The following is a description of a gene set: species: Homo sapiens from publication Schaefer CF, Anthony K, Krupa S, Buchoff J, Day M, Hannay T, Buetow KH (PMID 18832364) Syndecan-1-mediated signaling events Human Gene Set: PID_SYNDECAN_1_PATHWAY, and this is the list of marker genes: COL4A3, COL5A1, PRKACA, COL3A1, COL8A1, MET, SDC1, TGFB1, MMP1, COL8A2, COL4A4, COL4A1, COL17A1, MMP9, COL16A1, COL7A1, COL9A3, COL9A2, BSG, COL2A1, COL12A1, COL11A2, COL10A1, COL6A2, COL15A1, COL9A1, COL5A2, MAPK1, HPSE, CASK (calcium/calmodulin dependent serine protein kinase), COL6A1, LAMA5, COL6A3, COL11A1, MMP7, COL13A1, COL4A5, HGF, MAPK3, COL1A2, CCL5, COL1A1, COL14A1, SDCBP, PPIB, COL4A6